Given this list of marker genes CCNA2, E2F3, CCNA1, E2F1, CDK2 (NCBI Gene Id 1017), here is a description of the gene set: This is one of two 'gap' phases in the standard eukaryotic mitotic cell cycle. It is the interval between the completion of DNA synthesis and the beginning of mitosis. Protein synthesis occurs in this phase, following DNA replication in the S phase. This is the time when the cell stockpiles on the cytoplasmic contents, before mitosis and cytokinesis occur. species: Homo sapiens Reactome Pathway: G2 Phase part of: Mitotic G2-G2/M phases